The following is a description of a gene set: Human Gene Set: MIR4502 studied in species Homo sapiens from publication Chen Y, Wang X (PMID 31504780) Genes predicted to be targets of miRBase v22 microRNA hsa-miR-4502 in miRDB v6.0 with MirTarget v4 prediction scores > 80 (high confidence targets)., and this is the list of marker genes: ZNF705A, DDHD1, STAM2, FXR1 (NCBI Gene Id 8087), DCUN1D1, TOP2A, ZNF776, TOR2A, LHFPL1, PLCE1, ZNF781, SULF1, FKBP4, ZNF37A, ARFGEF1, ZNF268, RAB3GAP2, SLC4A8, PAH, MMP28, ZNF544, UBE2A, SLC8A2, GPM6B, TTC38, PALS1, SESN3, ZNF267, SPAG9, ZNF578, AADAT, SYNGR3, PPP4R3B, CACNA2D3, CPEB4, FKTN, KDM5A (NCBI Gene Id 5927), SAMD4A, TRPC5, PCDH17, TMPRSS13, ZNF354B, DNAJC24, PCMTD1, TMEM184C, AGO2, WASHC4, ZNF302, SMC1A, PLPP4, RBBP9, SRSF1, INTS2, TCOF1, TCF12, NDUFAF5, BCAT1, PPP2R5A, OFD1, HS3ST4, AVL9, PIAS2, CAVIN4, ZKSCAN7, LRCH3, ZFP90, RB1CC1, PHACTR2, LMLN, HELZ, DDX4, UGDH, ZFP1 (ZFP1 zinc finger protein), GABRA4, MYO1B, ZNF189, SLC38A4, DBT, GRPEL2, EIF5A2